The following is a description of a gene set: Mouse Gene Set: chr7E3 species: Mus musculus, and this is the list of marker genes: Or51f1, Or51aa5, Or51e1, Or52e19 (olfactory receptor family 52 subfamily E member 19), Or52e51-ps1, Or5p65-ps1, Gm18907, Gm5053, Or52m2, Tub, Or52z14, Olfr515-ps1, Or52f1-ps1, Hbb-bh1, Or5p75-ps1, Olfml1, Or51a8, Or5p5, Trim30c, Or51f5, Gm17989, Trim21, 4930458B22Rik, Or51t4, Gm8667, Apbb1, Gvin-ps5, Or10ab5, Trim5, Or51v15-ps1, Or51i1, Hbb-bh2, Gm25636, Nlrp10, Trim68, Gvin-ps3, Or52e54-ps1, Or52u1, Or51u1-ps1, Or51a43, Or51f1e, Or52e8, Or2ag18, Or51ag1, Gm27150, Or2ag13, Gm5338, Or10a3, Cavin3, Or5p51 (NCBI Gene Id 258417), Or2ag16, Or52d3, Gm16336, Usp17le, Ubqln5, Lyve1, Gm4972, Or5p1, Or52e4, Or51h7, Gm17992, Gm9064, Or52a33, Gm17990, Or52k2, AA474408, Hbb-bh3, Or52n2, Or51a6, Usp17ld, Trim30e-ps1, Lmo1, Or52a5b, Gm9105, Gm45392, Zfp143, 5430402P08Rik, Or51a5, BC051019, Or52h7, Or5p5c-ps1, Usp17lc (NCBI Gene Id 13532), Gm8913, Or52ad1, Gm24210, Mrpl17, Or51af1, Or10a3b, Gm16464, Or2d3, Or10a4, Or5p54, Or51ac3 (olfactory receptor family 51 subfamily AC member 3), Ric3, Or5p53, Tmem41b, Gvin2, Olfr468-ps1, Or2d2, Trim30a, Gm21123, Or52a20, Or51q1c, Or51f23b, Dennd5a, Adm, Gm6574, Or56b34, Or5p80, Or5e1, Gm17219, Or51k2, Gm10087, Or52n20, Or52e5, Or5p72, Nlrp14, Or52e53-ps1, Or2d3b, Trim12c, Gm10156, Taf10, Or5p74-ps1, Ampd3, Hbb-y, Or51v8, Gm15133, Or5p79 (NCBI Gene Id 258738), Or5p57, Or5p76, Cyb5r2, Or2ag19, Gm23100, Or51d1, Or51ab3, Stk33, Or5ag1-ps1, Trim12a, Gvin1, Or52b4i, Or5p66, Or51f23 (olfactory receptor family 51 subfamily F member 23), Dnajc19-ps, Or2ag20, Ilk, Or2ag15 (olfactory receptor family 2 subfamily AG member 15), Ctr9, Eif3f, Or52e19b, Or52x1 (NCBI Gene Id 259072), Or51v14, Or56b35, Or52a24, Or5p6, Or51i2, Or51l1-ps1, Gm9449, Or52ab7, Or51q1, Zbed5-ps, Or52i2, Sbf2, Gm44611, Or6i1-ps1, Or52m1, Or51a39, Trim6, Or56a3b, Dchs1, Or51h5, Or52r1b, Usp17la, Gvin-ps4, Or51g2, Or52s1b, Or51ah3, Or10ab4, Gm5339, Or51m1, Or51a25, Or52e7, Or52h2, Or51a44-ps1 (olfactory receptor family 51 subfamily A member 44, pseudogene 1), Or51a3-ps1, Or5p67, Gm24846, Or51aa2, Or56a41, Or52n5, Or5p52, Or5p55, Ubqln3, Or52n4, Or51b6b (NCBI Gene Id 259126), Hbb-bs (hemoglobin, beta adult s chain), Or52ab4, Or52c1-ps1, Gm15115, Or51l4, Gm27228, Rbmxl2, Or52b4j-ps1, Or55b10, Gm2996, Or52e3, Trim30d, Or51a41-ps1, Rnf141, Or52d1, Or52d13, Timm10b, Or52p2, Olfr511-ps1, Or2ag14-ps1, Dennd2b, Or5p58, Or52e15, Or51a42, Or52r1, Or10a3n, Or51v16-ps1 (olfactory receptor family 51 subfamily V member 16, pseudognee 1), Tpp1, Or52j3, Or6a2, Or51l14, Or6b6, Gm6007, Or10a49, Eif4g2, Or13n4, Or51a10, Or51a7, Or52s19, Or52n2b, Gm5900, Or5p56, Or51k1, Usp17le-ps (NCBI Gene Id 675359), Cckbr, Or52s6, Or52z12, Hbb-bt, Swap70, Or2d3c, Or51a24 (olfactory receptor family 51 subfamily A member 24), Or52z13, Or5p50, Trim66, Or10a5, Or56a5, Or51e2, Gm24888, Gm22372, Or10a2, Or5p71-ps1, Or56b1, Or52s1, Arfip2, Or5p63, Snora3, Gm15645, 1700095J03Rik (NCBI Gene Id 74293), Or5p61, Or52z15, Or51k4-ps1, Or55b3, Or2ag2, B430319F04Rik, Or52r6-ps1, Or51k7, Trim34a, Or52ae7, Or51h1, Or52b2, Gm9132, Cnga4, Or2ag2b, Olfm5, Or51s1, Or52ac1, Ovch2, Platr28, Or51b4, Nrip3 (NCBI Gene Id 78593), Rpl27a, Gvin-ps2, Or5p81, Gm45331, Or52n2c, Gm18255, Or52n21-ps1, Or5p77-ps1, Ascl3, Gm44781, Or51f1d, Or52a5, Or52b4, Gm22504, 1600010M07Rik, Or2ag12, Gm4887, Fhip1b, Gvin-ps6, Or52p1, Rrm1, Trim3, Or52ae6-ps1, Gm8556, Or51f2, Gm5901, Or52b1, Irag1, Or56b2l-ps1 (NCBI Gene Id 404412), Akip1, Or5p60, Or2d4, Gm3765, Or5p59, Or52e18, 5330417H12Rik, Or51f4-ps1, Hbb-bh0, Or52ab2, Or51f23c-ps1, Snora23, Gm23262, Or52r1c, Gm19127, Or52b3 (NCBI Gene Id 259105), Hpx, Gm4199, Or51b17, Or52ab8-ps1, Gm4886, Ubqlnl, Or5p73, Or5p69, Trim30b, Or5p78, 4930516K23Rik, Mrps36-ps2, Or51ai2, Smpd1, Or52n4b, Or52ae9, Rrp8, Or10a48, Or5p62, Or5p68, Or56a4, Or52e2, Syt9, Or52h1, Or5p4, Gm5002, Or51b6, Or56b2j, 4930431P19Rik, Wee1, Or52n3, Or56b6, Or2d36 (olfactory receptor family 2 subfamily D member 36), Or51r1, Trim34b, Tmem9b, Or2ag17, Or52w1, Gvin-ps7, Or56b2, Or51p1, Or52l1, Gm28863, Gm19033, Or6b9, Gm17991, Or52n1, Gm8982, Or55b4, Ppfibp2, Or2ag1, Or5p64, Gvin-ps1, Gm18410, Or2ag1b, Or51k3-ps1, Gvin3, Ipo7, Or2d2b, Or52z1, Or52b6-ps1, Dnhd1, Scube2, Or10a3m, Gm18944, Or5p70, Or56a42-ps1, Or52e8b, Gm6593, Or56b1b, Usp17lb, Or56a3, Or51g1, Or52h9, Gm15116, Gm6702